Given this list of marker genes RAB11FIP3, FOXD1, C1QTNF1, CRHBP, DAB2, IL1B, HCAR2, BMP6, RAB11FIP5, CGA, PPARG, KCNK9, TACR2, KCNQ1, GATA3, CRHR1, AQP1, TRPV6, SMAD4, GNRHR, AGTR1, GHRL, CYP19A1, SPP1, RAB11FIP1, REN (renin), RAB8B, INHA, GAL, RETN, LEP, NKX3-1, NIBAN2, TSPO, GALR1, FZD4, APLN, UCN, INHBB, FOXL2, NPVF, POMC, AGT, FGFR1, C1QTNF3, WNK4, CRH, ECRG4, TMF1, INHBA, KDM5B, TBX3, GJA1, SELENOM, TAC1, CRY1, PTPN11, GDF9, OPRK1, CRY2, here is a description of the gene set: studied in species Homo sapiens Human Gene Set: GOBP_ENDOCRINE_HORMONE_SECRETION The regulated release of a hormone into the circulatory system.